The following is a description of a gene set: Human Gene Set: GOMF_CALCIUM_DEPENDENT_PROTEIN_BINDING Binding to a protein or protein complex in the presence of calcium. studied in species Homo sapiens, and this is the list of marker genes: DMBT1, TNNC1, CRNN, SELP, PDCD6IP, S100A9, RAC3, S100G, S100PBP, S100A7L2, ANXA2, VAMP2, CLN3, CLEC4M, S100A4, SYT1 (synaptotagmin 1), ANXA11, FCN2, ANXA1, VPS37B, PDCD6, SYN1, S100A12, S100A7, S100A1, S100B, CALM2, SPACA9, CASQ2, A2M, MASP1, MASP2, S100A11, S100A8, ANXA3, CALM3, TNNT3, SYT8, VPS37C, S100A10, RBM22, PLSCR3, S100A16, CALM1, CPNE3, STX1A, CABP1, ANXA4, S100Z, LRP8, CPLX2, S100A5, NRXN1, ANXA7, SLC24A4, SLC9A1, S100A14 (NCBI Gene Id 57402), TNNI3, SNTN, ANXA6, S100A3, SNAP25, S100A6, STX2, MBL2, VLDLR, CHP1, S100P, STMN2, SEC31A, S100A13, CD177, MYO1D (myosin ID), NOS1, S100A2, S100A7A, DDX5, TSG101, NSMF, PEF1, WFS1